The following is a description of a gene set: studied in species Homo sapiens Human Gene Set: GOBP_POSITIVE_REGULATION_OF_SYNAPSE_MATURATION Any process that increases the extent of synapse maturation, the process that organizes a synapse so that it attains its fully functional state., and this is the list of marker genes: ANAPC2, NEURL1, RELN, CAMK2B, DAB2IP, CDC20, NEUROD2, NRXN1